Given this list of marker genes Ccl17, Ehd1, Psmb8, Arpc1b, Mthfsl, Plk2, Ncoa7, Stat1, Myo1g, Tspo, Adprh (ADP-ribosylarginine hydrolase), Zfand6, Uchl3, Wars1, Bcl2l11 (BCL2 like 11), Gclc, Dtx3l, Cfl1, Zbp1, Cxcl10, Cytip, Fgl2, Irf1, Tspan13, Cxcl9, Gbp4, Isg15, Ggta1, Macroh2a1, Ccnd2, S100a11, Fyco1, Orai1, Tap2, Grk2, Mier3, Pkib, Nup88, Tagln2, Rap2a, Prdm1, Cdkn1a, Noct, Bcl2a1b, Gbp2, Ccdc71l, Stxbp6, Prkcd, Atrx, Clta, Dclre1c, Nudt17, Cmtm6, Fabp5, Gpbp1, Lrrk1, Ikzf4, Gbp5, Cish, Arid5a, H2-Eb1, Rasa2, Zbtb38, Ifi35, Stat2, Gbp7, Basp1, Ifi47, Pdlim5, Il10ra, Igtp, Ctsz, Eif3a, Plgrkt, Cd302, Ly96, Vim, Syngr2, Gnb4, Aff1, Pfn1, Traf5, Eif1a, Nr4a3, Lmo2, Diaph1, Lima1, Psen2, Tap1, Spi1, Irf8, Ly75, Litaf, Cst3, Bcl2a1a, S100a10, Irgm2, Csf2rb, Rel, Nrp2, Rap2b, Ptpn1, Plac8 (placenta-specific 8), Selplg, Magt1, Csrp1, Mir155hg, Cd274, Atp6v0a1, C1qbp (NCBI Gene Id 28127), Map3k1, Atp11a, Parp9, Foxn2, Necap2, Jaml, Tmem70, Akap9, Pdcd1lg2, Arl1, Ifi27l2a, Chd7, Psma7 (NCBI Gene Id 26444), Irgm1, Rap1b, Luc7l3, Nckap1l, Csnk1d, Tubb2a, Serpinb6b, Eloc, Sh3glb1, Ndrg1, Coro2a, Pim1, Pnp, Eif5a, Parp14, Glipr2, Sphk1, Slfn2, Tmem165, Coro1a, Dse, Nfya, Wipf1, Samhd1, Cnn3 (calponin 3, acidic), Irf5, Malt1, Myl12a, Socs1, Zc3h7a, Nampt, Rpain (NCBI Gene Id 69723), Eif4a1, Ppa1, Eif2s1, Casp4, Pik3r5, Cd86, Serpina3g, Iigp1, here is a description of the gene set: species: Mus musculus from publication Cui A, Huang T, Li S, Ma A, Pérez JL, Sander C, Keskin DB, Wu CJ, Fraenkel E, Hacohen N (PMID 38057668) Genes positively differentially expressed in cell type: MigDC (migratory dendritic cell) upon treatment with cytokine: IL-18 in mouse lymph nodes in vivo. Cytokines mediate cell-cell communication in the immune system and represent important therapeutic targets. A myriad of studies have highlighted their central role in immune function, yet we lack a global view of the cellular responses of each immune cell type to each cytokine. To address this gap, the authors created the Immune Dictionary, a compendium of single-cell transcriptomic profiles of more than 17 immune cell types in response to each of 86 cytokines (>1,400 cytokine-cell type combinations) in mouse lymph nodes in vivo. A cytokine-centric view of the dictionary revealed that most cytokines induce highly cell-type-specific responses. For example, the inflammatory cytokine interleukin-1β induces distinct gene programmes in almost every cell type. A cell-type-centric view of the dictionary identified more than 66 cytokine-driven cellular polarization states across immune cell types, including previously uncharacterized states such as an interleukin-18-induced polyfunctional natural killer cell state. Mouse Gene Set: CUI_MIGDC_IL18_RESPONSE_UP